The following is a description of a gene set: Mouse Gene Set: GOMF_OXYGEN_CARRIER_ACTIVITY studied in species Mus musculus Binding to oxygen and delivering it to an acceptor molecule or a specific location., and this is the list of marker genes: Ngb, Hbb-bh1, Hbb-y, Hbb-bh2, Hba-a1, Hbq1b, Hbb-bs, Hbb-bt, Mb, Hbb-bh0, Hbq1a, Hba-x